The following is a description of a gene set: electronically inferred by orthology from the curated human pathway part of: Neuronal System Reactome Pathway: Transmission across Chemical Synapses This event has been computationally inferred from an event that has been demonstrated in another species.<p>The inference is based on the homology mapping from PANTHER. Briefly, reactions for which all involved PhysicalEntities (in input, output and catalyst) have a mapped orthologue/paralogue (for complexes at least 75% of components must have a mapping) are inferred to the other species. studied in species Mus musculus, and this is the list of marker genes: Tomt, Ppfia3, Cplx1, Nsf, Slc6a3, Grin2c, Chrne, Dlg4, Gng5, Kcnj3, Slc22a1, Gabrr3, Gabrq, Camkk1, Grik5, Aldh2, Syn1 (NCBI Gene Id 20964), Lin7b, Grin2a, Slc22a2, Stx1a, Slc1a7, Gnb2, Cacnb3, Cacng3, Camkk2, Gabra1 (gamma-aminobutyric acid type A receptor subunit alpha 1), Gls2, Gabra4, Prkacb, Ap2b1, Gng7, Dlg3, Chrna4, Kcnj5 (NCBI Gene Id 16521), Slc38a2, Plcb3, Chrnb2, Ppfia2 (NCBI Gene Id 327814), Gnb5, Calm1, Chrna7, Gng3, Gabrb3 (GABRB3, gamma-aminobutyric acid type A receptor subunit beta 3), Ap2m1, Epb41l1 (erythrocyte membrane protein band 4.1 like 1), Adcy5, Gabrr2, Cacng4, Prkcg, Gng10, Rab3a, Nefl, Htr3b, Grin2d, Gnat3, Rps6ka6, Gabra3, Gabrr1, Cacnb1, Camk2b, Camk1, Slc6a1, Gngt2, Gngt1, Ap2s1, Htr3a, Grip1, Tspoap1, Prkca, Slc6a13, Slc1a6, Prkaca, Glra2, Grin1, Gnb3, Adcy8, Ap2a1, Grin2b, Vamp2, Syn3, Adcy7, Kcnj2, Prkar1b, Prkar2b, Kcnj12, Cacna1a, Kcnj10, Gabra6, Gnai1, Gabbr1, Gng11, Cacna2d2, Slc17a7, Cacna2d3, Gng4, Slc5a7, Gng8, Syt1